The following is a description of a gene set: from publication Chaussabel D, Semnani RT, McDowell MA, Sacks D, Sher A, Nutman TB (PMID 12663451) Human Gene Set: GSE360_T_GONDII_VS_M_TUBERCULOSIS_MAC_UP Monocyte-derived dendritic cells (DC) and macrophages (MΦ) generated in vitro from the same individual blood donors were exposed to five different pathogens, and gene expression profiles were assessed by microarray analysis. Responses to Mycobacterium tuberculosis and to phylogenetically distinct protozoan (Leishmania major, L. donovani, Toxoplasma gondii) and helminth (Brugia malayi) parasites were examined, each of which produces chronic infections in humans yet vary considerably in the nature of the immune responses they trigger. studied in species Homo sapiens Genes up-regulated in comparison of macrophages exposed to T. gondii versus macrophages exposed to M. tuberculosis., and this is the list of marker genes: SERPINE2, ATP2A2, STK10, MCM2, TXNRD1, ACP5, IL3RA, KPNA3, MCM6, ISL1, GLB1, CTBP1, COL7A1, TRAF5, PCGF1, KHSRP, EEF1B2, MARCKSL1, NEO1, CLSTN1, CXCR4, CH25H, TTC1, COL19A1, WEE1, EZR, NHP2, PXDC1, LBX1, POLDIP3, TCF25, C2CD2, PLIN1, DNM1, ID3, IQCK, TYMS, CCN5, SLC7A5, POLR2H, B4GALT2, IGFBP7, PLRG1, SLC39A14, FUT1, CEACAM1, HEXIM1 (HEXIM P-TEFb complex subunit 1), TPD52L2, GAB1, C1orf216, CEP250, EZH2, RUVBL2, NAP1L4, STOML2, BRD3, HES1 (NCBI Gene Id 3280), CDKN1C, RNASE3, UBTF, TKT, TARBP1, PFKL, ASNS, MAGEB2, HEXA, PRDX2, IL1R1, KHDRBS3, TBX19, PABPC1, KCTD7, RORA, THAP11, RRAS2, SELE, HSD3B2, CPSF4 (NCBI Gene Id 10898), TLR5, RPS21, ALDH1B1, JADE2, GATA2, ARB2A, PPBPP2, MNT, ATIC, DNAH7, CDK4, BMERB1, PIK3R3, CCL2, GPNMB, SLC2A2, RASSF1, MCF2L, RPL9, RIN1, LPAR2, TRAP1, DDIT3, CCR7, CLOCK (clock circadian regulator), ABL1, CNPPD1, MUC2 (NCBI Gene Id 4583), LMNB1, SLC16A5, SMOX, DHRS1, HTR2B, TMEM11, TRIM28, CHERP, BRD2, HOMER1, NBL1, GADD45A, LAMP3, GSK3B, MYOZ2, NCALD, KLHL21, PLEKHA6, KCNA3, TRIB1, PMM1, PC, ASMTL (acetylserotonin O-methyltransferase like), CDIPT, NUP188, GPC3, TMEM184B, TUBB7P, PABPC4, CDT1, FAM131A, SLC5A3, SLC1A5, PECAM1, DNAJC9, H4C2 (H4 clustered histone 2), FLNB, ZNF175, INPP5A, MRTFA, PATZ1, GADD45B, NCOR2, NMT2, SPECC1L, PIK3IP1, RNF187, TXLNA, TP53BP2, NCL, IMPA2, CERS6, IRF5, PMS1, AFG3L2, IRF4, PRIM1, ORC4, MYO1A, ADGRG6, SAC3D1, PTDSS1, DOCK10, SYN2, RANBP1, PFKFB1, BHLHE40, USP20, VAT1, H2BC12, SLC6A8, REL, CLIC5, UBN1, ADCY9, TFAP4, TOMM34, MSH6, FABP5, PTGER3, NREP, IMPDH2, MISP, PON2, TRA2A, HMGA1 (NCBI Gene Id 3159), POLR3C, PACS2, ALDH1A2, CD83, MSH2, NEFH, CRYAA